Given this list of marker genes UQCRH, MT-CYB, UQCRFS1, UQCRC2 (NCBI Gene Id 7385), UQCRC1, UQCRQ, UQCRHL, UQCRB, UQCR11 (ubiquinol-cytochrome c reductase, complex III subunit XI), CYC1, UQCR10, here is a description of the gene set: studied in species Homo sapiens Electron transfer in Complex III. Pathway ID: N00990. Pathway type: Reference. Pathway class: nt06252 Mitochondrial ROS formation. Pathway Definition from KEGG: QH2 -- CxIII -> CytC Human Gene Set: KEGG_MEDICUS_REFERENCE_ELECTRON_TRANSFER_IN_COMPLEX_III